The following is a description of a gene set: Mouse Gene Set: GOBP_NEGATIVE_REGULATION_OF_PROTEIN_AUTOPHOSPHORYLATION species: Mus musculus Any process that stops, prevents or decreases the rate of the phosphorylation by a protein of one or more of its own residues., and this is the list of marker genes: Cav1, Tesk1, Mvp, Jun, Gfra2, Ptprc, Errfi1, Enpp1, Adipoq, Nlrp12, Chp1